The following is a description of a gene set: Pathway Definition from KEGG: PSEN1* -> GSK3B -| (KIF5+KLC) studied in species Homo sapiens Mutation-caused aberrant PSEN1 to anterograde axonal transport. Pathway ID: N01017. Pathway type: Variant. Pathway class: nt06460 Alzheimer disease. Human Gene Set: KEGG_MEDICUS_VARIANT_MUTATION_CAUSED_ABERRANT_PSEN1_TO_ANTEROGRADE_AXONAL_TRANSPORT, and this is the list of marker genes: KIF5B, GSK3B, KIF5A, KIF5C, KLC2, PSEN1, KLC4, KLC3, KLC1